Given this list of marker genes LDB3, AGRN, SNUPN, MARS1, LRP4, LMNA, RAPSN, POLG, COLQ, MUSK, COL13A1, AK9, DYSF, HINT1, MFN2, BICD2, MYH7, GNE, REEP1, GJB1, HARS1, NEFL, GARS1, HSPB3, FLNC, PMP22, GYG1, CHRNA1, TIA1, SCN4A, DOK7, MORC2, DCTN1, CHRND, PNPLA2, LAMB2, NEB, CHRNB1, TK2, BSCL2, MATR3, YARS1, PDK3, RTN2, CADM3, GDAP1, SQSTM1, SBF2, TTN, CAV3, CHRNE, here is a description of the gene set: studied in species Homo sapiens Hand muscle weakness Human Gene Set: HP_HAND_MUSCLE_WEAKNESS Reduced strength of the musculature of the hand.